Given this list of marker genes AHRR, BMAL2, AHR (NCBI Gene Id 196), ARNT, HSP90AB1, ARNT2, BMAL1, AIP, here is a description of the gene set: Human Gene Set: GOCC_ARYL_HYDROCARBON_RECEPTOR_COMPLEX A protein complex that acts as an aryl hydrocarbon (Ah) receptor. Cytosolic and nuclear Ah receptor complexes have different subunit composition, but both contain the ligand-binding subunit AhR. species: Homo sapiens